Given this list of marker genes Yy1, Ino80d, Nfrkb, Ino80b, Ino80c, Ino80, Tfpt, Ruvbl2, Mcrs1, Actr8, Actr5, Actl6a, Uchl5, Ruvbl1, here is a description of the gene set: Any process that activates or increases the frequency, rate or extent of telomere maintenance in response to DNA damage. Mouse Gene Set: GOBP_POSITIVE_REGULATION_OF_TELOMERE_MAINTENANCE_IN_RESPONSE_TO_DNA_DAMAGE studied in species Mus musculus